The following is a description of a gene set: Genes down-regulated in comparison of naive CD4 T cells versus unstimulated memory CD4 CD8 T cells. Immune cell-specific expression is one indication of the importance of a gene's role in the immune response. In order to identify such patterns, we set out to broadly profile gene expression in a variety of immune cells. species: Homo sapiens Human Gene Set: GSE22886_NAIVE_CD4_TCELL_VS_MEMORY_TCELL_DN from publication Abbas AR, Baldwin D, Ma Y, Ouyang W, Gurney A, Martin F, Fong S, van Lookeren Campagne M, Godowski P, Williams PM, Chan AC, Clark HF (PMID 15789058), and this is the list of marker genes: TUT7, RCHY1, CCND2, TRAPPC11, VPS33A, N4BP2L2, TMED2, ELK3, GBP1, ERGIC2, LRRC8D, SSTR1, TOR1A, CCPG1, RHPN1-AS1, TPM1, ANKH, GPN3, PBXIP1, INTS5, CD96, CALM1, NOC3L, CAB39, ARL6IP5, CREBL2, SIRT1, ST8SIA1 (ST8 alpha-N-acetyl-neuraminide alpha-2,8-sialyltransferase 1), LTB, PMS1, GLOD4, CPEB3, RIOK2, GLRA1, GCG, GALNT7, CCL20, IFIH1, TRIP4, TM9SF2, CEP57, FPGT, FUT8, WDR76, ST8SIA4, EID1, ATG101, DIPK1A, PNP, SLAMF1, GLUD1, PRDX1, USP1, PPM1D, TMEM50B, SHOC2, SRSF5, ATP5F1A, CHN1, LPCAT4, FANCE, TBPL1, NCK1, DYNLT3, COPB2, GLT8D1, ARHGAP15, STXBP3, KIF5C, GPR63 (G protein-coupled receptor 63), TCF12, SEC61G, ZFR, WTAP, CCR4, DCK, TNKS2, MEOX1, TPM4, VPS4B (vacuolar protein sorting 4 homolog B), CPOX, KCMF1, PARK7, CKLF, SEM1, HMOX2, GINS1, GOLGA5 (golgin A5), TTF2, RDX, GPKOW, EMC2, SNX5, ARHGEF6, SKP1, SLC39A8, LRIG1, CNBP, ASF1A, NEK4 (NIMA related kinase 4), KDM3B, IFT57, NUP62, SORL1, TMEM123, ABRAXAS2, COPS4, MID1IP1, MICU2, DPY19L4, ERLIN1, ANKRD27, UBA2 (NCBI Gene Id 10054), SUPT16H, DAZAP1, MTRR, GIMAP4, TPD52L2, UFM1, DIABLO, PTPRCAP (protein tyrosine phosphatase receptor type C associated protein), DNAAF2, GET1, PEX13, ZNF133 (zinc finger protein 133), DSTNP2, PLP2, GABARAPL2, TAF5, ZFP36L1, UNG, SEC11A, GRK6, UBL4A, MRFAP1L1, ORC2, CISD1, SDF2, EIF2S2, C21orf91, LPAR6 (NCBI Gene Id 10161), HIGD1A, MGAT2, GPD1L, NDUFV2, RNF34, KARS1, HPS5, RWDD1, NKAPD1, RTRAF, TRAF5, GTF2H1, PDCD4, CMPK1, CRKL (NCBI Gene Id 1399), ISOC1, IL6R, CCDC47, SLC35G2, RBL1, ACAP2, ARF6, ZBTB6, AQP3, MRPL15, TUFT1, PIGV, FASTKD3, TBL3, ENOPH1, ADSL, PCNX4, TSNAX, RDH11, PNMA1, YWHAZ, HECA, CDC6, MAEA, GIMAP6, ZFAND6, CD28, JRKL, CCDC90B, ARL1, TMCO1, RPS6KA3, DHDDS, CBLL1, GAPVD1, GALK2, MCM6, XPOT, GRAP2, GCN1, NBR1, CCL18, TLK1, MTREX